Given this list of marker genes FCN2, MASP2, FCN1, FCN3, MASP1, here is a description of the gene set: studied in species Homo sapiens Reactome Pathway: Ficolins bind to repetitive carbohydrate structures on the target cell surface Ficolins are recognition molecules in the lectin pathway of complement activation. Three types of ficolin have been identified in humans: M-ficolin (ficolin-1, FCN1), L-ficolin (ficolin-2, FCN2) and H-ficolin (ficolin-3, FCN3). FCN2 and 3 circulate in blood plasma whereas FCN1 is locally secreted by immune response cells. Plasma ficolins circulate as complexes with MBL-associated serine proteases (MASPs). Upon binding of ficolins to carbohydrates on the target cell surface, MASPs are activated and subsequently activate the complement cascade. Ficolins function as trimers and larger oligomers. Ficolin peptide sequences contain an amino-terminal cysteine-rich region, a collagen-like domain, a neck region and a carboxy-terminal fibrinogen-like domain. The fibrinogen-like domain binds to pathogen- or apoptotic cell-associated molecular patterns. Different ficolins have distinct recognition specificities. part of: Lectin pathway of complement activation